The following is a description of a gene set: Mouse Gene Set: GOMF_TRANSCRIPTION_REGULATOR_ACTIVITY studied in species Mus musculus A molecular function that controls the rate, timing and/or magnitude of gene transcription. The function of transcriptional regulators is to modulate gene expression at the transcription step so that they are expressed in the right cell at the right time and in the right amount throughout the life of the cell and the organism. Genes are transcriptional units, and include bacterial operons., and this is the list of marker genes: Zfp366, Sall1, Zfp280b, Kdm3a, Sox6, Zfp566, Onecut3 (one cut domain, family member 3), Zfp873, Hivep2, Chd4, Msc, Rorc, Gm17655, Foxo1, Aip, Nfatc2, Nkx2-9, Hoxc10, Pax1, Lpin1, Smarca4 (NCBI Gene Id 20586), Sox15, Grhl1, Ascl3, Gata4 (GATA binding protein 4), Rhox2h, Cbfb, Foxe3 (forkhead box E3), Ascc1, Six1, Zfp444, Ncoa6, 5730507C01Rik, Mxi1, Cebpa, Cops2, Uxt, Zfhx2, Zbtb17, Kdm1a, Zfp707, Rlf, E2f6, Pias1, Niban2, Sirt6, Bhlhe40, Zfp37 (NCBI Gene Id 22696), Parp14, Trim37, Dhx9, Mlxip, Skor1, Duxf3, Zbtb7b, Kmt5a, Med1, Tlx2, Eny2, Msx3, Sox1, Mzf1, Prkn, Rfx1, Gm14443, Hes3, Grhl2, Trib3, Gm14418, Rslcan18, Gcm1, Ets2, Actn2, Pbx1, Tbx20, Elk4, Mga, Foxj2, Zfp946, Tead1, St18, Bsx, Tcf15, Eno1, Klf1, Sp4, Sri, Bcl11b, Nr1d1, Carm1, Hmx2 (NCBI Gene Id 214938), Atmin, Zbed6, Meox2, Tbx15 (NCBI Gene Id 21384), Atxn7l3, Med13l, Taf1, Wdr77, Sohlh2, Csrnp1, Sox10, Zscan4b, Hoxd12, Nfat5, Zfp354b, Atf4, Sub1, Hoxb9, Ylpm1, Klf11, Zfp451, Zfp1007, Smad3, Rhox3c, Cdc5lrt1, Srebf1, Zfp523, Nr1h4 (nuclear receptor subfamily 1, group H, member 4), Zfp169, Gata1, N4bp2l2, Tfap2b, Zfp334, Trim24, Ruvbl2, Med27, Tshz1, Gm4767, Zfp429 (NCBI Gene Id 72807), Zfp236, Prdm5, Trim62, Gm12258, Dlx2, Zfp712, Id2, Egr2, Dmrta1, Zfp746, Irx5, Rhox7b, Hcfc1, Tada1, Zfp938, Zfp768, Kat6b, Pbx4, Tsg101, 2610008E11Rik, Gm14322, Wt1, Zbtb22, Irx2 (NCBI Gene Id 16372), Nr1i2 (nuclear receptor subfamily 1, group I, member 2), Zbtb45, Foxn1, Zfp518a, Zfp316, Obox3, Zfp683, Hoxc12, C1qbp, Erf, Zfp992, Duxbl1, Lyar, Cdc5lrt6, Wwtr1, Hoxd4, Esr1, Gbx1, Stat6, Zxdb, Foxa2, Twist1 (NCBI Gene Id 22160), Isl1, Zfp382, Med7, Nfyc, Etv1, Hipk2, Ss18, Prmt5, Snip1, Pitx1, Akirin2, Pex14, Zscan4-ps1, Lef1, Hoxc4, Zfp697, Zfp729a, Zfp472, Ppargc1b, Hes1, Zfp639, Rhox13, Smarcb1, Mypop, Cc2d1a, Hoxb3, Ddx1, Mynn, Taf6, Zfp637, Ovol3, Ube3a, Mbtps2, Zfp513, Zfp994, Jun, Taf3, Ahdc1, Med10, Tox3, Zbtb33, Kdm5a, Ncoa7, Rhox7a, Fhl2, Elf4, Gsdmd, Zfp507, Gata3, Spdef, Med26 (mediator complex subunit 26), Rhox3a, Zfp30, Smarcd2, Npas3, Tcf21, Nfatc3, Nacc2, Hsf2, Smad2, Tlx1, Zfp991, Camta1, Cbfa2t3, Hoxb13, Nr3c1, Kmt2c, Zfp81, Zfp868, Tal2, Dmrtc1c1 (DMRT-like family C1c1), Camta2, Prpf6, Gpbp1, Vdr, Pou3f2, Gata6, Zfp3 (zinc finger protein 3), Or51e2, Tead3 (NCBI Gene Id 669027), Hoxc6, Zfp352, Rfx6, Maml2, Zbtb11, Rara, Lmo4, Zfp867, Insm1, Zic2, Yy2, Hdgf, Sim2, Hsf1, Ptpn14, Hes5, Ube2l3, Zfp69, Zfp790, Foxb2, Hes7, Batf2, Foxo3, Zfp341, Nkx2-1, Gcm2, Hoxc9, Irf7, Nfkbil1, Zfp941, Tcp10c, Zfp408, Zfp810, Trim25, Hdac9, Lmo3, Cdk9 (NCBI Gene Id 12574), Nfxl1, Hand1, Hic2, Gm19965, Zgpat, Hlx, Crym, Hoxd1, Zfp59, Homez (NCBI Gene Id 239099), Zfp944 (NCBI Gene Id 381069), Nkx2-2, Prop1, Klf4, Fos, Tle5, Hnf1b, Rsl1, Zfp820, Pou3f3, Nr1h5, Zfp24, Prdm16, Zscan4f, Trim12c, Hoxc11, Sim1, Arrb1, Creb3l4, Isx, Bbx, Zfp607b, Hnf4g (NCBI Gene Id 30942), Zbtb1, Tbr1, Glis1, Phf10, Foxj1, Bcl10, Dlx6 (NCBI Gene Id 13396), Rel, Wnt4, Rfxank, Jdp2, Tbx21, Zfp110, Grhl3, Tfb2m, Hoxa6, Gm3604, Stk3, Tcerg1, Zfp92, Nr2e3, Med12l, Mlx, Nfil3, Zfp764, Zfp997, Zfp983, Arnt, Tbx6, Dcc, Zfp709, Zbtb10, Zfp865, Med8, Tle3, Mta3, Ikzf5, Maf, Men1, Zscan10, Etv6, Zfp763 (zinc finger protein 763), Kdm2a, Vgll2, Hoxa2, Zfp410, Pprc1, Zic1, Ikzf1, Taf9, Yeats2, Dyrk1a, Id4, Zfp281, Irf1, Cebpb, Pou2f3, Bcor, Zfp524, Maz, Zfp934, Trim31 (tripartite motif-containing 31), Purb, Hhex, Foxl3, Jade1, Sox21, Basp1, Heyl, Tle6, Tada2b, Zcchc12, Kat2a, Zfp626 (zinc finger protein 626), Brd8, Sp7, Foxf1, Id1, Tle4, Park7, Eid2b, Zfp1010, Vax1, Plagl2, Zbtb47, Zbtb4, Zkscan17, Tsc22d1, Zkscan16, Preb, Rhox1, Ascl2, Acss2, Nrl, Zfp568, Qki, Cebpg, Zfp775, Zfp74, Nfkb2, Keap1, Hoxa13, Lmo1, Yap1, Rfxap, Nipbl, P2rx2 (purinergic receptor P2X, ligand-gated ion channel, 2), Foxn2, Sox13, Neurod6, Gmeb1, Rhox4d, Mesp1, Zfp787, Rbpj, Rcor3, Olig3, Zfp1006, Zfp536, Prkcb, Zfp120, Hdx, Zscan25, Zbtb37, Zfp811, Hsbp1l1, Kat2b, Notch4, Taf15, Mta2, Wbp2, Trim32, Runx3, Pou5f1, Zfp82, Cdyl, Tfap2e, Prdm14, Zfp616, Crebbp, Zglp1, Zfp286, Mecom, Jup, Myt1l, E2f3, Zfp628, Zfp607a, Zfp951, Hoxa7, Smad4, Meis1, Tbx1, Zeb1, Zfp930, Hspa1a, Fhl3, Zscan20, Rere, Zbtb34, Smad7, Gm5141, Zfp579, Patz1 (NCBI Gene Id 80645), Trim15, Hsf5, Zfp961 (NCBI Gene Id 77912), Zfp677, Zscan4d, Pou2f2, Arid5b, Zfp984, Zfp692, Zfp976, Csrnp2, Sox14, Esx1, Pou6f2, Nfic, Hdac3, Cux1, Zfp583, Irf5, Zfp580, Zbtb9, Bmal2, Myc, Med11, Zfp937, Hoxd8, Bclaf1, Zfp995 (NCBI Gene Id 70081), Casp8ap2, Aebp2, Zfp119a, Irx1 (NCBI Gene Id 16371), Zfp324, Zfp932, Sp9, Trim14, Tmf1, Smarcd1, Samd7 (sterile alpha motif domain containing 7), Irf6, Hoxd10, Mxd1, Asah1, Fiz1, Etv2, Mak, Nkx2-6, Irx3, Hnf4a, Rhox2d, Mitf, Lhx6, Zfp582, Nkx3-2, Mier2, Supt20, Evx1, Zkscan8, Zfp966, Lbx2, Zfp711, Cic, Hey1, Elk3, Ovol2, Nrbf2, Zfp180, Alx4, Mef2a, Spz1, Zfp260, Nrf1, Mybl2, Stat2, Ppard, Prdm11, Elf3, Dmrt1, Myf6, Zfp942, Stat5a, Zfp362, Zfp454, Mtf1, Mxd3, Arx, Foxb1, Foxi1, Mnt, Zscan12, Tbl1xr1, Gm2381, Nfe2l3 (nuclear factor, erythroid derived 2, like 3), Rreb1, Zfp850, Nr2c1, Paqr8, Zfp821, Rxra, Atf7ip, Kcnip3, Tlx3, Sohlh1, Phf24, Zxdc, Pou5f2, Isl2, Meis2, Brca1, Fhl5, Smad1, Cdc5lrt5, Zhx1, Atoh8, Rxrg, Zfp369, Zscan4c, Psmd9 (NCBI Gene Id 74214), Ets1, Foxj3, Zfp131, Foxr1, Thrap3, Pax2, Elk1, Pir, Zfp449 (zinc finger protein 449), Tfcp2, E2f2, Tob1, Bcl11a, Myrf, Zbtb21, Zfp740, Wbp2nl, Arid3a, Gm14412, Zfp825, Pias2, Jund, Fosl1, Zbtb41, Trim12a, Foxm1, Dnmt3b, Irx6 (Iroquois homeobox 6), Foxe1, T, Barx1, Usf1, Dlx5, Irx4, Myt1, Tcf7l1, Zfp747l1, Fli1, Rfx2, Rhox2f, Raly, Creb3l2, Mms19, Foxp1, Zfp964, E2f7, Rap2c, Foxl1, Riox2, Gli2, Zfy1, Spic, Zscan21, Zfp518b, Zfpm1, Rhox9, Runx1, Gsc2, Litaf, Zfp955b, Uri1, Zfp426, Pcbp1, Ikzf2, Med6, Rfx8, Eid1, Zfp384, Hoxb5, Nkx2-4, Zfp367, Zfp653, Gm6871, Rfx3, Jmy, Skil, Klf9, Nacc1, Nfe2l1 (nuclear factor, erythroid derived 2,-like 1), Zfp689, Kat8, Sfr1, Rora, Zfp777, Pou2f1, Fbxl19, Phb1, Dmrta2, Cnot9, Foxd3, Meis3 (NCBI Gene Id 17537), Six3, Ldb2, Cdc5lrt9, Gm35315, Zfp263, Sp140l2, Olig2, Aff3, Zmynd11, Hoxa10, Notch1, Pus1, Wtip, Zbtb14, Sp8, Zkscan6, Ark2n, Pias3, Zfp97, Trim28, Zfp758, Myf5, Klf13, Ehf, Pkd2, Zbtb26 (zinc finger and BTB domain containing 26, NCBI Gene Id 320633), Mier3, Barx2, Zfp28, Tgfb1i1, Hand2, Ncoa1, Wwox, Cdc5lrt8, Zbtb40, Zfp704, Pml (NCBI Gene Id 338524), Irf9, Hmga2, Rhox2a, Prdm2, Carf, Zfp866, Myrfl, Irf2bp1, Zkscan2, Yaf2, Zbtb25, Med24, Nobox, Zfp982, Klf14, Elf1, Sp140l1, C1d, Zfp772, Trim38, Barhl2, Sap30, Emx1, Dach2, Zfp985, Casz1, Zfp442, Esrrb, Zfp119b, AI987944, Zscan29, Crtc1, Nkx1-2, Kctd15, Med15, Bhlhe23, Zfp219, Zscan4-ps3, Neurog3, Zfp791, Zfp882, Sox18, Irf2bp2, Zfp981, Lyl1, Rfx4, Hoxa1, Zfp398, Aebp1, Zmiz1, Sox17, Pax7, Gm15446, Zbtb16, Zfp457, Zscan4e, Mafb, Obox8, Zfp612, Zfp977, Rad54l2, Sox9, Gm14403, Cdca4, Pgr, Hif1a, Mef2d, Usp22, Clock, 2010315B03Rik, B020011L13Rik (NCBI Gene Id 547097), Zbtb42, Tfap2d, Dmtf1l, Phf12, Ep300, Pknox1, Hoxc5, Kctd1, Zfp959, Zfp322a, Med30, Tbx22, Sertad1, Neurog1, Phox2b, Foxp2, Zfp446, Ruvbl1, Esr2, Etv4, Flywch1, Sox5, Vhl, Fezf2, Insm2, Gper1, Nrg1, Ewsr1, Spib, AU041133, En2, Med17, Nr4a2, Lmcd1, Pou1f1, Dbp, Zfp963, Yy1, Nr3c2, Nab1, Otx2, Ccdc124, Hoxd9, Hivep3, Calcoco1, Zbtb3 (zinc finger and BTB domain containing 3), Mkx, Hmx3, E2f4, Gm14444, Zfp987, Trim30c, Kdm7a, Prdm4, Med31, Zeb2, Bhlha9, Utf1, Ptf1a, Ascl4, Trp63, Daxx, Hoxa4, Bnc1, Scrt1, Zfp182, Klf2, Zfp935, Tdg, Zfp280c, Xpc, Zbed4, Zbtb7a, Lpxn, Bach1, Nfkbiz, Rhox4b, Zmynd8, Zfp128, Zfp516, Zfp668, Etv3l, Pou3f1, Nr2f6, Spen, Zbtb48, Ctcf, Mybbp1a, Rhox8, Rhox2b, Zfp87, Snai2, Arid5a, Vsx2, Sox4 (NCBI Gene Id 20677), Trim27, Atf2, Hic1, Cdc5lrt10, Polr2m, Zfp1005, Ar, Zfp599, Sin3a, Cdkn2a, Sox2, Tbx4, Zfp68, Trim30d, Dyrk1b, Zfp874b, Eaf2, Rbak, Ajuba, Btaf1 (NCBI Gene Id 208902), Irf3, Ascl5, Creb3l3, Hinfp, Gsc, Prox2, Glis2, Bcorl1, Nr5a1, Zfp719, Parp1, Pasd1, Foxk1, Bhlhe22, Vezf1, Med21, Rorb, Prdm1, Nkx2-3, Phox2a, Ebf1, E4f1, Zbtb8a, Mybl1, Atoh7, Smad6, Ezh1, Hoxb7 (NCBI Gene Id 15415), Nfya, Pax4, Zbtb12, Tcf12, Med14, Snw1, Hipk3, Nrip1, Rhox6, Zfp940, Dmrtc2, Sox3, Cux2, Sp2, Zfp869, Nfatc4, Tead4, Snai3 (snail family zinc finger 3), Med13, Bhlhe41, Fgf2, Bicra, Six6, Parp9, Zfp14, Nkx6-3, Phf2, Eid2, Elf5, Pou4f2, Mycs, Elane, Mef2c, Hivep1, Zfp617, Sap30l, Lmx1b, Msx2, Zfp143, Mideas, Klf3, Zbtb8b, Bcl3, Atf1-ps, Dlx3, Zfp654, Trim30b, Zfp433, Lpin2, Pou4f3, Arnt2, Zbtb20, Foxc2, Tcerg1l, Plagl1, Zkscan7, Zfp949, Egr1, Zfp563, Hoxa9, Glis3, Pou2af1, Ifi204, Stat4, Brd4, Deaf1, Gm14391, Rbpms, Atf6, Tdrd3, Dach1, Rhox3h, Nsd3, Kdm3b, Platr25, Mysm1, Kdm4c, Nkx1-1, Uncx, Usp16, Tbx5, Zfp213, Egr4, Hmgb1, Zfp39, Tfdp1, Hoxb4, Zfp784, Trerf1, Psip1, Hoxa5, Rhox4a, Sox8, Gli1, Foxd2, Cdx4, Zfp988, Irf2, Vax2, Zbtb43, Zfp512b, Npm1, Hr, Zfp1, Hes6 (NCBI Gene Id 98321), Hdac7, Foxi2, Map3k10, Adnp, Pou6f1, Ciao1, Emx2 (NCBI Gene Id 13797), Thrb, Foxd1, Esrra, Taf6l, Atn1, Runx1t1, Asxl1, Plscr2, Pax5, Dmrt2, Pkm, Ncoa2, Zhx2, Cir1, Nupr1, Zfp41, Cd274, Foxa1, Zfp85, Zfp710, En1, Tfcp2l1, Zfp809, Plag1, Thap11, Klf7, Tfec, Sall4, Tgif1, Mrtfa, Lhx2, Hmgb2 (high mobility group box 2, NCBI Gene Id 97165), Mamstr, Foxo4, Zic3, Cebpz, Foxa3, Zfp870, Actn1, Rhox3g (reproductive homeobox 3G), Trim52, Zkscan4, Gata5, Hdac5, Foxs1, Ecsit (NCBI Gene Id 26940), Med20, Ddx17, Actn4, Notch2, Pknox2, Birc2, Fosl2, Zfp42, Zfp623, Zfp455, Crebl2, Rfx7, Dnajb1, Zfp423, Hes2, Taf5l (NCBI Gene Id 71789), Foxh1, Limd1, Usf2, Six5, Zfp558, Zfp551, Esrrg, Cmtm2a (NCBI Gene Id 73381), Nr6a1, Foxn3, Atf5, Creb5, Mafk, Zfp971, Zbtb49, Dmrtb1, Zfp239, Dmap1, Pdx1, Tcp10a, Nkx6-2, Nkx3-1, Zbtb6, Foxk2 (NCBI Gene Id 76149), Stat1, Zfp641, Parp10, Hsf4, Nr1h3, Zfp418, Zfp438, Twist2, Naca (NCBI Gene Id 404597), Hdac1, Myog, Zfp715, Brd7 (NCBI Gene Id 27017), Pou4f1, Pa2g4, Mnx1 (motor neuron and pancreas homeobox 1), Setd5, Mesp2, Uaca, Trp73, Lhx5, Cited1, Foxr2, Foxd4, A430033K04Rik, Peg3, Creb3l1, Srf, Klf17, Zfp672, Hnrnpu, Tfap4, Rnf20, Figla, Zfp7, Spi1, Zfp871, Cdc5l, Xbp1, Jazf1, Supt3, Alx3, Zfp397, Eomes, Zfp175 (NCBI Gene Id 210104), Zfp345, AI854703, Elob, Ankrd1, Zfp354a, Prrx2, Tcf7, Cited2, Csrnp3, Zfx, Zfp998, Zfhx4, Nkrf, Hnf1a, Tcfl5, Lhx4, Zbtb5, Zfp952, Olig1, Rarg, Zfp273, Sap18, Duxf4, Msgn1, Obox2, Tbl1x, Tfdp2, Zfp13, Foxg1, Zfp874a, Zfp647, Tox2, Zfp956, Aff1, Eno1b, Lpin3, Gsx1, Onecut2, Bcl9, Pmf1, Dlx4, Ctcfl, Nup98, Atf7ip2, Tada3, Pou2af3, Zfp1004, Zfp980, Drgx, Hmga1b, Zfp708, Zfp943, Nsd1, Zscan26, Nr4a3, Noto, Nr2c2, Zfp146, Zfp541, Nr1h2, Arl2bp, Zic4, Cops5, Zfp275, Zc3h8, Vsx1, Ahr, Gm14401, Zbtb46, Foxq1, Satb1, Tcf3, Zfa-ps, Cys1, Bclaf3, Klf15, Muc1, Atf1, Nanog, Rrp1b, Klf5, Paqr7, Bmal1, Zfp729b, Gm45871, Gata2 (NCBI Gene Id 14461), Zscan5b, Trappc2b (trafficking protein particle complex 2B), Usp21, Mycn, Zfp597, Trim5, Ncor1, Zbtb18, Ncoa3, Rxrb, Zfp691, Sin3b, Zfp747, Crtc2, Zfp456, Hoxd13, Cdc5lrt7, Mef2b, Zfp105, Cenpj, Zfp973, Gli3, Six2, Taf11, Zfp933, Ccar1, Hoxd11, Nr2f2, Npas1, Hsf3, Zfp12, Zfp663, Prox1, Fus, Tada2a, Zfhx3, Sp3, Shox2, Maged1 (MAGE family member D1), Zfp696, Mecp2, Thap1, Ing4, Tgif2, Zfp280d, Runx2, Zfp975, Hoxc8, Zfp160, Nfib, Kmt2e, Med12 (mediator complex subunit 12), Mta1, Tbx3 (T-box 3), Dmtf1, Arid3c, Kat7, Lmx1a, Tle1, Ldb1, Cdc5lrt4, Zfp248, Klf8, Tacc1 (transforming, acidic coiled-coil containing protein 1), Hif1an, Hdac4, Zfp54, Sox11, Npat, Ctbp1, Slc30a9, BC024063 (NCBI Gene Id 675867), Zhx3, Med9, Tfeb, Mlip, Rhox4f, Zfp101, Rbm14, Gm14434, Zkscan3 (NCBI Gene Id 72739), Hoxb6, Mycl, Npas4, Helt, Klf6, E2f8, Zfp317, Tbx19, Tefm, Zfp9, Pou3f4, Nr2f1, Thra, Scx, Tshz2, Dlx1, Tbx2, Rest, Rela, Dot1l, Pde3a, Zfp667, Sp6, Hoxc13, Crxos, Ccnd1, Zfp65, Srebf2, Fosb, Mcidas, Zfp560, Zfp78, Rbpjl, Pura, Lhx3, Sry, Lmo2, Zkscan1, Foxp4, Hoxa11, Ovol1, Setd4, Zfp931, Zfp90, Zfp189, Creb3, Otx1, Tfap2a, Ddx54, Mtdh, Mid2, Ahrr, Relb, Pitx2, Trim13 (tripartite motif-containing 13), Hyal2, Hoxb2, Foxi3, Zfp217, Pou2af2, Sp5, Myb, Obox7, Zfp420, Cited4, Pax9, Arglu1, Gtf2ird1, Nucks1, Gm14325, Med18, Osr2, Hif3a, Pbx3, Rhox12, Gm7072, Dmrtc1b, Msx1, Ferd3l (Fer3 like bHLH transcription factor), Ddx5, Klf16, Smarcd3, Cnot7, Sertad2, Sqstm1, Zscan4-ps2, Zfp266 (zinc finger protein 266), Zfp764l1, Bmyc, Zscan2, Bcl9l, Nfe2, Sall3, Lhx9, Dbx1, Rpf2, Zbtb24, Tcf25, Nfatc1 (nuclear factor of activated T cells, cytoplasmic, calcineurin dependent 1), Zfp655, Atf7, Gps2, Ski, Foxf2, Prmt2, Irf8, Irf4, Jmjd6, Obox1, Nfkb1 (nuclear factor of kappa light polypeptide gene enhancer in B cells 1, p105), Fev, Rcor2, Nhlh1, Zfp157, A630001G21Rik (RIKEN cDNA A630001G21 gene), Satb2, Zfp53, Bcl6, Lbx1, Rhox10, Mycbp, Zfp383, Apex1, Zfp251, Zbtb2, Gabpa, Zfp853, Pparg, Zfp648, Zfp970, Smarca2, Tfe3, Kdm2b, Smyd1, Ezh2, Dmrt3, Tcf20, Rhox4g, Pkd1, Maml3, Med22, Nr2e1, Mxd4, Hoxb1, Hcfc2, Prdm8, Sox7, Zfp664, Kdm5b, Crebrf, Rhox11 (NCBI Gene Id 194738), Pdlim1, Atf3, Ppara, Samd11, Pax3, Rhox3f, Nfx1, Prrx1, Ascl1, Gmnn, Tcf4, Lhx1, Nhlh2, Zfp644, Creb1, Ncor2, Maff, Sav1, Zfp84, Stat3, Rbbp8, Nr5a2, Hmga1, Tle2, Pax6, Sra1, Gon4l, Zfp141, Zfp202, Foxc1, Trps1, Ebf3, Trp53, Rhox5, Mafa, Sp110, 2810021J22Rik (RIKEN cDNA 2810021J22 gene), Mier1, Nme2, Skor2, Pbx2, Zfp459, Cebpe, Zbtb38, Neurod2, Zbtb32, Plscr1 (NCBI Gene Id 54533), 4930522L14Rik, Gzf1, Pbxip1, Junb, Tef, Akirin1, Max, Nr1d2, Hoxd3, Per2, Lrrfip1, Setd3, Wnt3a, Rhox2g, Hsbp1, Epas1, Hmx1, Crx, Zfp872, Barhl1, Tcf23, Jph2, Eaf1, Ikzf4, Cdyl2, Zfp296, Ikzf3 (IKAROS family zinc finger 3), Egr3, Lhx8, Klf12, Kmt2d, Mixl1, Zfp773, Zfp58, Ssbp3, Prdm10, Tfap2c, Hexim1, Mlxipl (MLX interacting protein-like), Rhox4e, Gmeb2, Scai, Ebf2, Ebf4, Zkscan14, Med29, Med16, Zfp148, Pitx3, Foxo6, Tcf24, Rybp, Cbfa2t2, Zfp799, Npas2 (NCBI Gene Id 18143), Tfam, Maml1, Zfp2, Bach2, Zfp955a, Jmjd1c, Zfp846, Tcp10b, Atoh1, Zfp958, Cdx1, Ccdc62, Zfp358, Cphx1, Zfp575, Arap1, Pias4, Obox5, Trim21, Pkn1, Mafg, Nr1i3, Tead2, Tfb1m, Nfia, Zfp292, Erfl (NCBI Gene Id 632501), Kat6a, Zfp174, Ss18l1, AW146154 (expressed sequence AW146154), Zfp72, Zim1, Trip4, Tcf7l2, Nfix, Zfp395, Kat5, Taf12, Otp, Zfp750, Lcor (ligand dependent nuclear receptor corepressor), Sox30, Crem, Gm4924, Id3, Nr4a1, Hoxb8 (homeobox B8), Zfp184, Zfp960, Trim8, Gm10033, Sall2, Zic5, Foxn4, Zfp287 (zinc finger protein 287), Wwc1, Sfmbt2, Dmbx1, Phf8, Dmrtc1a, Zfp329, Tle7, Rcor1, Sdr16c5, Nfyb, Rarb, Myef2, Nab2, Zfp125, Snai1, Neurod1, Zmiz2, Ctnnb1, Tshz3, Nfkbia, Tob2, Klf10, Mrtfb, Usf3, Neurod4, Zfp386, Sox12, Purg, Tbx10, Evx2, Crtc3, Pcbd1, Scrt2, Hesx1, Zscan22, Smad5, Zfp493, Gtf2i, Myocd, Hey2, Zfat, Gfi1b, Drap1, Zkscan5, Elf2, Sfmbt1, Neurog2, Cdx2, Zik1, Nkx6-1, Myod1, Zfp212, Ppargc1a, Dhrs7b, Gfi1, Zfp46, Noc2l, Hlf, Ddn, Batf, Hipk1, Sp100, Supt7l, Batf3, Sirt1, Osr1, Zbtb39, Gsx2, Obox6, Crebzf, Cc2d1b, Gbx2, Dcaf6, Foxl2, Stat5b (signal transducer and activator of transcription 5B), Pax8, Nfe2l2, Trp53bp1, Rhox2c, Gm32687, Ddit3, Zfp979, Zfp652, Zfp954, Tbx18, Zfp990 (NCBI Gene Id 101056073), Fezf1, Sp1, Smad9, Alx1, Gm14399, Zfp113, Zbtb7c, Ctbp2, Zfp989, Hoxa3, Med19, Zfp879 (zinc finger protein 879), Rbfox2, Etv5, Zfp819, Etv3, Bend6, Cebpd, Nr0b2, Hbp1, Erg, Onecut1, Rhox4c, Zfpm2, Wiz, Bhlha15, Bcl6b, Abhd2, Med4, Btg2, Meox1, Trim30a, Ubp1, Zfp534 (NCBI Gene Id 102641588), Zfp947, Rax, E2f5, Rex2, Wdr43, Foxp3, Nr0b1, Six4, Edf1, Nkx2-5, Tal1, Rfx5, Atf6b, Psmc3ip, Cnot6, Trrap, Zfp354c, Zfp950, Bud31, Irf2bpl, E2f1